The following is a description of a gene set: We demonstrate that the G protein Gi3 is the cellular target of the adenosine A3 receptor (A3R). By using a cell permeable peptide comprising the C-terminal end of Gαi3 fused to an importation sequence (ALL1) as a selective inhibitor of Gi3 signaling, we show that by coupling to Gi3, the A3R stimulates multiple signaling pathways in human mast cells, leading to upregulation of cytokines, chemokines and growth factors.Following contact with activated T cell membranes, endogenous adenosine binds to and activates the A3R, resulting in Gi3-mediated signaling. Specifically, the majority of ERK1/2 signaling initiated by contact with activated T cell membranes, is mediated by Gi3, giving rise to ALL1-inhibitable cellular responses. These results unveil the physiological GPCR that couples to Gi3 and establish the important role played by this G-protein in inflammatory conditions that involve adenosine-activated mast cells. We used microarrays to detail the effect of ALL1 on gene expression of HMC-1 cells activated directly by the A3 receptor, or by contact with activated T cell membranes. studied in species Homo sapiens Genes down-regulated in HMC-1 (mast leukemia) cells: Cl-IB-MECA versus incubated with the ALL1 peptide followed by treatment with Cl-IB-MECA. Human Gene Set: GSE19888_ADENOSINE_A3R_ACT_VS_A3R_ACT_WITH_A3R_INH_PRETREATMENT_IN_MAST_CELL_DN from publication Baram D, Dekel O, Mekori YA, Sagi-Eisenberg R (PMID 20190146), and this is the list of marker genes: BAZ1B, MRS2, ELAVL1, IP6K2, ZBTB33, STAT2, CENPC, CES3, FBP2, GBA1, CMPK2, MX2 (NCBI Gene Id 4600), JAKMIP2, TRIM27, TBC1D9, RFC5, SLC45A4, ADRA1A, TOR3A, UBE2L6, CHCHD10, LCMT2, PLEKHM3, RSAD2, MPP2, LGALS3BP, USP25 (NCBI Gene Id 29963), PHYKPL, ANKZF1, UPP1, IBTK, RNF213, SOD2, TASOR, PLA2G4E, NUP188, RLIM, MLST8, RBSN, RAE1, HELZ2, INSL6, TBCB, XAF1, SLC25A22, FCGR3A, DAB1, MC1R, TAB3, TMEM252, ISG15 (ISG15 ubiquitin like modifier), GPR37L1, WDR55, NLGN2, PARP14, TTR, FUT8, RIGI, MIOS, SSC4D, CXCL11, ARF3, HCFC2, IFI35, ATP6V1A, TRIB3, IL15RA, GDF11, ZNF365, WDR62, ECE2, YJEFN3, BAHD1, BCO2, HROB, OMA1, P2RY2, CLEC1B, CD69, GZMB, KIF5C, ISG20, KLRK1, TEN1, IFIT3, IRF7, SAA1, COX18, PKP4, GLS, MAP9, TTC16, TLR3, GBP6, ACKR4, NRN1L, NGB, MISP, ANKRD37, GABRD, CDH23, OTOS, VSIG10, PRKX, SAP30, TMCC1, ZCCHC2, CHRNA4, POP7, DCUN1D2, DPH5, TAPBP, FURIN, MFSD6L, CXCL10, IFIT1B, MCM8, ELL2, DBH, COX15, EML4, PRMT9, HCK, CENPJ, SLC7A1, UNKL, ANGPTL6, NPL, ZNF335, DEDD, STAT1, TTLL11 (NCBI Gene Id 401550), PRPF6, GFUS, CRYGS, TIMM10, RPA1, RPL36A, CEP290, POLE2, ZNF385B, USP31, ALKBH4, LGALS9B, FABP5, TMPO, IFIT1, CASQ2, EIF2AK4, RNMT, CDT1, MFSD13A, UBA7, CD200 (NCBI Gene Id 4345), TMIGD1, CLCA1, ATP1A1, MAVS, TATDN1, ACY1, WNK3, DHX58, CKMT2, VIL1, PSMD12, DPYSL5, CDKN2AIPNL, TCIRG1, ENPP4, POU4F1, SNPH, GATA2, SGSM2, MLLT11, CYP1B1, CLBA1, LRRC75B, ATP5F1A, TMIE (NCBI Gene Id 259236), USP18, TPSG1, BSN, LIPC, CCDC6, NR3C2, SENP3, HERC6, NMT1 (NCBI Gene Id 4836), MYCBP2, SLAMF8, CXCL9, IRGM (immunity related GTPase M), CCDC59, NANOG, TNFSF10, EP400, SLFN12L, ZSCAN10, BIRC6